Given this list of marker genes SMAD4, NTHL1, MLH1, BMPR1A (NCBI Gene Id 8035), APC, GREM1, MSH2, here is a description of the gene set: A malignant epithelial tumor with a glandular organization that originates in the duodenum. species: Homo sapiens Duodenal adenocarcinoma Human Gene Set: HP_DUODENAL_ADENOCARCINOMA